The following is a description of a gene set: Coxa valga Coxa valga is a deformity of the hip in which the angle between the femoral shaft and the femoral neck is increased compared to age-adjusted values (about 150 degrees in newborns gradually reducing to 120-130 degrees in adults). species: Homo sapiens Human Gene Set: HP_COXA_VALGA, and this is the list of marker genes: IFIH1, MAN2B1, FUCA1, CCDC47, HSPG2, CRKL, SLC10A7, EED, EXT2, UFC1 (NCBI Gene Id 51506), COL1A1, SLC35A2, DVL3, TGFB3 (NCBI Gene Id 7043), NGLY1, PRKAR1A, SIL1, HNRNPH1, CANT1, COL1A2, NRCAM, COL9A3, ARID1B (AT-rich interaction domain 1B), GALNS, SLC2A10, RBM8A, SLC35B2, GJB2, GLI3, OTUD5, FLNA, EXT1, BCR, B3GALT6, ABCC9, ERCC6, ORC1, WNK3, EIF2AK3, EXTL3, ADAMTS2, B4GALT7 (beta-1,4-galactosyltransferase 7), GLB1, MGAT2, FZD2, RPS6KA3 (NCBI Gene Id 6197), SHOX, COL2A1, DVL1, MAPK1, HNRNPK, ENPP1, ADAMTSL2, TGFB1, PDE4D, GJB6, STXBP1, RTL1, POP1, COL9A1, IDUA, ARCN1, HNRNPR, UBE3C, ZMPSTE24, GTF2E2, LMNA, BGN, KCNJ8, COL11A1, LMX1B, CSGALNACT1, TOMM7, KDELR2, SLC12A2, ATP7A, AFF3, NFIX, COG1, WNT5A, COG4 (component of oligomeric golgi complex 4), XYLT1, GNPTAB, ATRX, DLK1, COG8, TRIP11, CBFB, MEG3, EZH2, RAB23, COL9A2